Given this list of marker genes SDCBP, ARL4C (ADP ribosylation factor like GTPase 4C), ELF2, SP3 (NCBI Gene Id 6670), GADD45A, EFCAB14, BCL11A, BRWD1, EXT1, CDC14A, CDK17, CHD3, USP34, EPHA4, ASAH1, LEF1, SYNE1, TSN, SGSM2, AREG, IFFO1, MCF2L, PDE4B, KAT7, EXTL3, ARHGAP45, MZF1, MT2A, LGALS8, SNRK, RANBP2 (RAN binding protein 2), CALM1, TCF20, ZBTB1, BLCAP, AKAP8, CTSO, PIK3IP1, LSM14A (NCBI Gene Id 91161), TLE5, EIF3A, JADE2, EIF4G2, TCF7, S1PR1, PTPN4, UBE2J1, IL11RA, SRRM2, EIF5, MOAP1, WTAP, DUSP8, PRDM2, CXCR4, ATG13, TGFBR2 (NCBI Gene Id 7048), ATP2A3, RPS27, ELOA, AUTS2, RBM39, DLG5, BICRAL (NCBI Gene Id 23506), CAPN2, TUBB2A, FYB1, CASP4, TENM1, CYTH1, RPL23, MAP4K2, VPS13B, RGS1, PNISR, RPL27, DDX3X, TRANK1, ZNF428 (zinc finger protein 428), THUMPD1, ST3GAL6, ITGA6, PCMTD2, PI4KB, SYNE2, SUN2, MBNL1, ATXN7L3B, ARL2BP, PAX6, SOX4, ADD3, CIRBP, EIF1, DNAJB1, DNAJB6, RASGRP2, ALDH2, ARHGAP4, HLA-E, NFATC2IP, TNFAIP3, ITGA2B, DDX49, RPS29, RPL38, TAFAZZIN, CENPB, LITAF, DAAM1, TRIB2, LEPROTL1, UBE2G2, MCL1, CLN3, RPL32 (ribosomal protein L32), DDX5, LAMP1, SH3YL1, GPS2, RGS2, TXNIP, JUNB, CIAPIN1, GTF2B, UBA7 (ubiquitin like modifier activating enzyme 7), HERC2P3, GPR183, FASN, NXF1, FCHSD2, PTPRA, BTG1, GAB2, SPOCK2 (NCBI Gene Id 9806), SRCAP, TRAM2, DNM3, VNN2, USP4, VAMP2, IFI44, CCDC69, DGCR2, MOB1A, PABPN1, HBP1, ABLIM1, RBM38, NME3, HEG1, DDIT3, MAN2B2, MPPE1, CTSK, NUCB2, FCMR, H1-10, CDC25B, RPL31, MAL, DAZAP2, TPP1, BTG2, LAPTM4A, HDAC5, CD37, NINL, SRSF6, TRAPPC12, H3-3B, TUBA1A, TDRD3, RRP8, TOB1, FLOT2, MFGE8, TNK2, PDE4D, TSPYL5, FOXN3, RGL2, PGRMC2, ISG20 (NCBI Gene Id 3669), SORL1 (sortilin related receptor 1), YWHAZ, AXIN1, SETD1B, TSC22D2, SARAF, IL7R, EPHB6, BCL2L11, RPS15A, SRGN, ITPKB, AKAP17A, PPP6R2, LAPTM5, ARHGEF18, here is a description of the gene set: Microarray analysis was performed to determine the transcriptional profiles of NKT, CD1d-aGC+ Va24-, and CD4 T cells. Genes down-regulated in activated T cells: CD4 versus Va24- NKT. from publication Constantinides MG, Picard D, Savage AK, Bendelac A (PMID 21632718) Human Gene Set: GSE28726_ACT_CD4_TCELL_VS_ACT_VA24NEG_NKTCELL_DN studied in species Homo sapiens